Given this list of marker genes PNPT1, FA2H (fatty acid 2-hydroxylase), KAT6A, PIGA, AFG3L2, TSEN54, VPS37A, TSEN15, MTRR (NCBI Gene Id 4552), ATRX (NCBI Gene Id 6475), MTPAP, SMG9 (SMG9 nonsense mediated mRNA decay factor), KDM5C, RNU7-1, ATL1, SDHA, SPG7, KIDINS220, TSEN34, SDHB, SLC33A1 (solute carrier family 33 member 1), ASXL1, GDAP2, SDHAF1, SEPSECS, SLC35C1, CLDN11, SLC39A14, SDHD, KIF5A (kinesin family member 5A), SPTAN1, ALDH18A1, TSEN2, RARS1, LBR, KDM1A, here is a description of the gene set: species: Homo sapiens Lower limb hypertonia Human Gene Set: HP_LOWER_LIMB_HYPERTONIA